Given this list of marker genes Adam33, Jup, Angptl4, Amot, Ctnnd1, Cdh11, Adam19, Ctnnb1, here is a description of the gene set: Regulation of CDH11 function studied in species Mus musculus Mouse Gene Set: REACTOME_REGULATION_OF_CDH11_FUNCTION